The following is a description of a gene set: Human Gene Set: HP_ABNORMALITY_OF_THE_EPIPHYSES_OF_THE_FEET species: Homo sapiens Abnormality of the epiphyses of the feet Any abnormality of the epiphyses of the feet., and this is the list of marker genes: COL9A2, COL9A3, MATN3, COL9A1, EIF2AK3, ARSL, TBC1D2B (TBC1 domain family member 2B)